Given this list of marker genes Slc25a23, Slc25a41, Slc25a4, Slc25a5, Slc25a24, Adcy10, Slc25a31, here is a description of the gene set: Mouse Gene Set: GOBP_MITOCHONDRIAL_ATP_TRANSMEMBRANE_TRANSPORT studied in species Mus musculus The process in which ATP is transported across a mitochondrial membrane, into or out of the mitochondrion.